The following is a description of a gene set: Genes positively differentially expressed in cell type: pDC (plasmacytoid dendritic cell) upon treatment with cytokine: EGF in mouse lymph nodes in vivo. Cytokines mediate cell-cell communication in the immune system and represent important therapeutic targets. A myriad of studies have highlighted their central role in immune function, yet we lack a global view of the cellular responses of each immune cell type to each cytokine. To address this gap, the authors created the Immune Dictionary, a compendium of single-cell transcriptomic profiles of more than 17 immune cell types in response to each of 86 cytokines (>1,400 cytokine-cell type combinations) in mouse lymph nodes in vivo. A cytokine-centric view of the dictionary revealed that most cytokines induce highly cell-type-specific responses. For example, the inflammatory cytokine interleukin-1β induces distinct gene programmes in almost every cell type. A cell-type-centric view of the dictionary identified more than 66 cytokine-driven cellular polarization states across immune cell types, including previously uncharacterized states such as an interleukin-18-induced polyfunctional natural killer cell state. Mouse Gene Set: CUI_PDC_EGF_RESPONSE_UP from publication Cui A, Huang T, Li S, Ma A, Pérez JL, Sander C, Keskin DB, Wu CJ, Fraenkel E, Hacohen N (PMID 38057668) studied in species Mus musculus, and this is the list of marker genes: Cfl1, Atp5mc1, Nme1, Napsa, Aldh9a1, Cfp